The following is a description of a gene set: The side of a membrane that faces the cytoplasm. species: Mus musculus Mouse Gene Set: GOCC_CYTOPLASMIC_SIDE_OF_MEMBRANE, and this is the list of marker genes: Gng11, Msn, Traf6, Myzap, Stac2, Alox15, Grk2, Efcab7, Ap2a2, Rnf31 (NCBI Gene Id 85306), Kcnip1, S100a6, Chuk, Gm2a, Cd2, Rab21, Ntsr1, Borcs7, Cyld, Diablo, Rasa3, Mien1, Gem, Farp1, Fes, Cabp1, Ajap1, Esyt3, Rps29, Osbpl2, Borcs6, Ppp3ca, Gnai2, Gfap, Ank1, Hid1, Sppl2a, Chmp4c, Sppl2c, Gna13, Snx18, Litafd, Jak2 (Janus kinase 2), Ptpn4, Plekha4, Myd88, Rasal3, Traf5, Tirap, Fgfr3, Ldlrap1, Dsg1b, Hck, Epb41, Cdk16, Gnai3, Rhoa, Iqce, Gnb2, Traf3, Dnaja3, Traf2, Jak3, Gnao1, Gnrh1, Ap2b1, Htra2, Ptpn7, Jak1, Gng13, Shroom4, Iqgap1, Borcs5, Alg5, Samd10, Gng4, Map2k2, Ikbkb, Fer, Ryr1, Gng7, Kcnab2, Npcd, Gng2, Epm2aip1, Rgs2, Gna14, Prmt8, Stac, Gnai1, Dsg1c, Dtna, Qtrt1, Ptpn22, Atp2b1, Syap1, Gna12, Gnat2, Pkp4, Birc2, Syt6, Dlg1, Alg13, Esyt2, Gng12, Pkd2 (polycystin 2, transient receptor potential cation channel), Ap2a1, Socs3, Akap5, Mapt, Rasgrp4, Mcf2l, Samd12, Ptpn3, Drd4, Chmp7, G6pdx, Ptp4a1, Gnat3, Gnal, Becn1, Ptprc, Spta1, Ppp1r9b, Ank2, Ap2s1, Rgs1, Epn3, Jup, Acp1 (NCBI Gene Id 80477), Otulinl, H13, Lrrk2, Ncf1, Alg1, Chmp4b, Ryr2, Loricrin, Snapin, Gnat1, Fkbp1a (FK506 binding protein 1a), Aspscr1, Stac3, Gnaq, Gng5, C2cd2l, Cfp, Gng14, Rps26, Ap4b1, Myh9, Gngt1, Fermt2, Micall1, Kcnab1, Gnaz, Rpl27, Rab5a, Slc4a1, Kras, Gnas, Ptpn1, Gna15, Dst, Cyth1 (NCBI Gene Id 19157), Myh10, Gng3, Th, Gngt2, Frmd6 (FERM domain containing 6), Snx5, Pgm5, Mtss1, Gng5c, Alg14, Gng10, Gnb5, Borcs8, Bloc1s2, Atp2c2, Bloc1s1 (NCBI Gene Id 14533), Cdip1, Epm2a, Pten, Rgs8 (regulator of G-protein signaling 8), Gnb4, Cnr2, Gphn, Kxd1 (KxDL motif containing 1), Mtss2, Tgm3, Atp2a2, Cdh1, Gna11, Cisd1, Gng8, Gnb1, Rps28, Nphs2, Lyn, Kit, Sppl3, Gnb3, Alg2, Nlrp10, Sppl2b, Racgap1, Litaf, G6pd2, Qtrt2, Ap2m1, Dsg1a, Ryr3, Itpr3